The following is a description of a gene set: A box H/ACA small nucleolar ribonucleoprotein complex located in the nucleolus that catalyzes pseudouridylation of ribosomal RNA residues. The complex is composed of four different core proteins that assemble onto a H/ACA guide RNA scaffold that identifies specific uridines in rRNA for modification during ribosome synthesis. Mouse Gene Set: GOCC_BOX_H_ACA_SNORNP_COMPLEX species: Mus musculus, and this is the list of marker genes: Dkc1, Nop10, Nolc1, Gar1, Nhp2